Given this list of marker genes AVP, DRD5, THRA, OXT, AVPR1A, PPP1R1B, FUOM, NCOA1, THRB, here is a description of the gene set: studied in species Homo sapiens Human Gene Set: GOBP_FEMALE_MATING_BEHAVIOR The specific behavior of a female organism that is associated with reproduction.